Given this list of marker genes LILRB2, PLOD3, LILRB3, TLR3, P4HA2, FCGR3A, PSG3, IGLL1, FCER1A, PLOD2, LGALS3, FCGRT, P4HB, FCER2, PLOD1, APOH, FCGR2A, HCP5, FCER1G, here is a description of the gene set: Genes in the cancer module 478. studied in species Homo sapiens Human Gene Set: MODULE_478